Given this list of marker genes DOCK5, INO80, NBPF3, TFDP1, CREB3L4, FPGS, CYP11B1, CMTM4, SYNE2, BRD4, HAND1, VPS36, ZNF608, GCC1, MAP2, MOV10, PABPC4L, RANBP10, JOSD1, AQP1, CACNA1A, PRKAR2A (protein kinase cAMP-dependent type II regulatory subunit alpha), CASKIN2, PHTF2 (NCBI Gene Id 57832), PAK2, CNTN2, CREB5, RPF2, HEY2, FOXO1, KIF3C, CRLF3, MAPKAPK3 (NCBI Gene Id 7867), ARMH3, NBPF15, FGFRL1, MEIKIN, SPTSSB, TRIM26, ARK2N, PCSK7, JARID2, SV2B, ADAM22, PITPNM2, OLFM2, USH2A, ZNF526, MBD3, UNC5CL, DGKH, SNX11, NACC2, GPR26, CEP72, PCDHB10, PDGFB, ABR, TRAF3, ERGIC2, CCNT2, NXPH4, AREL1, NAV1, TSPAN2, GJB1, BLMH, SKI, L3MBTL2, MINDY2, AMER1, EIF1AY, OTUD7A, KRT73, DNALI1, CAPN2 (calpain 2), CYP4A11, UTRN, VAMP2, PCDH1, H2BC5 (H2B clustered histone 5), TBC1D13, TLR9, ZSCAN2, EGR1, SLC39A10, ADORA1, COX7A2L, STAMBP, NBPF12 (NBPF member 12), LRRFIP1, GPR63, MAP4, SSBP3, SLC43A2, FBXL20, RPEL1, TBC1D2B, HIF1AN, DESI1, PPP1R11, SMARCAD1, ATP2B3, GABRB3, RIT2, FAM83B, RETREG2, OTUD6B, STUM, MBNL1, KSR2, NAA60 (N-alpha-acetyltransferase 60, NatF catalytic subunit), MYADM, NOTCH2, DENND10, U2SURP, CS, MOSPD1, ACRV1, ITPK1, GRB10, CREB1, BMF, LCE1E, MPIG6B, RNF123 (NCBI Gene Id 63891), SLAIN1, BBS5, GARRE1, COTL1, ATXN7L3B, ZNF250, CTTNBP2NL, CYP7A1, CDK16, FBXO45, AKAP13, KY, ANGPT2, N4BP1, INO80D, NAV2, TENM1, TMCC2, SGPP1, PTP4A2, ESR1, ST7L, ENTPD4, NBPF1, SMIM24 (NCBI Gene Id 284422), NBPF9, ZC2HC1C, FBF1, POU4F1, STRN, OR2C3, PARN, NFIL3, F8, SCN4B, NEXMIF, PNKD, CHMP7, WDFY3, WWP2, MLXIP, LBH, KCND3, ZER1, ITGB3BP, XRCC6, PIAS3, ACSBG2, ATP1B2, FBXO10, DIS3L2, EGFLAM, RAB11B, GRIK3, DOC2A, MYBBP1A, AVIL, TBC1D10A, CACNA1B (calcium voltage-gated channel subunit alpha1 B), LMO7, PRX, SH3BP2, CDC42EP4, PRM1, SH3GLB2, CEP164, SLC8A2, MAP3K9, KDM2A, SON (NCBI Gene Id 84155), SMLR1, SHISA7, WASF2, ASB6, SEMA4F, ZMAT3, HIGD1A, NPR3, IQCG, PLAAT5, SSR1, MYPOP, RAB11FIP4, RIMS4, PDCD1, DPP9, KL, RMND5A, TEX2, RNF44, MARCHF6, CYP8B1, TMEM9B, KIAA0513, HEG1, TRPC4AP, WASL, SYT1, NBPF8 (NCBI Gene Id 728841), RAB1B, TMPRSS6, SLC26A7, here is a description of the gene set: Genes predicted to be targets of miRBase v22 microRNA hsa-miR-4692 in miRDB v6.0 with MirTarget v4 prediction scores > 80 (high confidence targets). Human Gene Set: MIR4692 studied in species Homo sapiens from publication Chen Y, Wang X (PMID 31504780)